Given this list of marker genes ATP2B2, GNA14, HOMER3, PDK1, GRIA1, GNA11, PLCB4 (NCBI Gene Id 5332), GRIA4, GNA15, PLCB3, GNAQ, GRIA3, ITPR1 (NCBI Gene Id 619543), GRM1, TRPC3, RYR3, CA8, PLCB1, PRKCG, PLCB2, GRIA2, CACNA1A, here is a description of the gene set: species: Homo sapiens Human Gene Set: WP_PKCGAMMA_CALCIUM_SIGNALING_IN_ATAXIA PKC-gamma calcium signaling in ataxia